Given this list of marker genes EXTL1, NRK, H2BC21, CSPG4, COL9A3, CERCAM, FOXO3, GRIA2, MT-ND3, COL9A2, MRC2, GREM1, XYLT1, FLNB, COL11A2, WWP2, DDR2, SORBS1, MT-ATP6, MALAT1, FGFRL1, PER1, MMP16, NFIA, MT-ND4, LRP1, MT-CO3, MEG3, APOE, MATN1, MEG8, CADM2, DST, PHC3, MT-CYB, TRAM2, COL2A1, MON2, PXYLP1, SOX9, COL14A1, FMOD, PEG3, COL9A1, COL27A1, COL11A1, FAM53B, EBF1, here is a description of the gene set: from publication Su Z, Ho JWK, Yau RCH, Lam YL, Shek TWH, Yeung MCF, Chen H, Oreffo ROC, Cheah KSE, Cheung KSC (PMID 38267611) species: Homo sapiens The transformation of benign lesions to malignant tumours is a crucial aspect of understanding chondrosarcomas, which are malignant cartilage tumours that could develop from benign chondroid lesions. However, the process of malignant transformation for chondroid lesions remains poorly understood, and no reliable markers are available to aid clinical decision-making. To address this issue, we conducted a study analysing 11 primary cartilage tumours and controls using single-cell RNA sequencing. By creating a single-cell atlas, we were able to identify the role of endoplasmic reticulum (ER) stress in the malignant transformation of conventional central chondrosarcomas (CCCS). Our research revealed that lower levels of ER stress promote chondrosarcoma growth in a patient-derived xenograft mouse model, while intensive ER stress reduces primary chondrosarcoma cell viability. Furthermore, we discovered that the NF-?B pathway alleviates ER stress-induced apoptosis during chondrosarcoma progression. Our single-cell signatures and large public data support the use of key ER stress regulators, such as DNA Damage Inducible Transcript 3 (DDIT3; also known as CHOP), as malignant markers for overall patient survival. Ultimately, our study highlights the significant role that ER stress plays in the malignant transformation of cartilaginous tumours and provides a valuable resource for future diagnostic markers and therapeutic strategies. Human Gene Set: SU_HO_FOETAL_FEMUR_C1_RESTING_CHONDROCYTE Characterized by the expression of transcription factor SOX9, as well as type II, IV, and VI collagens (COL2A1, COL9A1, and COL11A1) associated with the production of cartilage matrix.